The following is a description of a gene set: from publication Stein RA, Chang CY, Kazmin DA, Way J, Schroeder T, Wergin M, Dewhirst MW, McDonnell DP (PMID 18974123) Genes down-regulated by ESRRA only. studied in species Homo sapiens Human Gene Set: STEIN_ESRRA_TARGETS_DN Expression of estrogen-related receptor alpha (ERRalpha) has recently been shown to carry negative prognostic significance in breast and ovarian cancers. The specific role of this orphan nuclear receptor in tumor growth and progression, however, is yet to be fully understood. The significant homology between estrogen receptor alpha (ERalpha) and ERRalpha initially suggested that these receptors may have similar transcriptional targets. Using the well-characterized ERalpha-positive MCF-7 breast cancer cell line, we sought to gain a genome-wide picture of ERalpha-ERRalpha cross-talk using an unbiased microarray approach. In addition to generating a host of novel ERRalpha target genes, this study yielded the surprising result that most ERRalpha-regulated genes are unrelated to estrogen signaling. The relatively small number of genes regulated by both ERalpha and ERRalpha led us to expand our study to the more aggressive and less clinically treatable ERalpha-negative class of breast cancers. In this setting, we found that ERRalpha expression is required for the basal level of expression of many known and novel ERRalpha target genes. Introduction of a small interfering RNA directed to ERRalpha into the highly aggressive breast carcinoma MDA-MB-231 cell line dramatically reduced the migratory potential of these cells. Although stable knockdown of ERRalpha expression in MDA-MB-231 cells had no effect on in vitro cell proliferation, a significant reduction of tumor growth rate was observed when these cells were implanted as xenografts. Our results confirm a role for ERRalpha in breast cancer growth and highlight it as a potential therapeutic target for estrogen receptor-negative breast cancer., and this is the list of marker genes: HPF1, CCNG2, CLDN3, RHBDF1, PDCL, EFCAB14, ARID4A, LAMB1, CYP1B1, EXOSC2 (NCBI Gene Id 23404), BRD3, OCLNP1, YPEL5, NAP1L1, PRKAR2B, MYO6 (myosin VI), CSNK1G2, TACC1, BRD3OS, TRIO, TFE3, CDC23, CYBC1, RGS19, SEPTIN8, PLAU, MARCKS, MSH6, INTS12, ZNF24 (NCBI Gene Id 7744), VANGL1, TRMT112 (tRNA methyltransferase activator subunit 11-2), RABIF, DHX40, ATG2B, PPL, PMM1, SEC14L1, SLC37A4, TNFRSF11B, RBFOX2, FGFR3, MORC2, ADRA2C, GNPDA1, DENND10P1, SIGMAR1, DGUOK, BPTF, KIDINS220, NR2F2, TERF1, ZNF7, UCK2, HLA-E, DCTD, ZHX3 (zinc fingers and homeoboxes 3), TNFAIP8, GTF2B, BOP1, GATAD1, TCAF1, HEXIM1, PRKD2, CAV2, TIGAR, ZNF45, DBNDD1, SLCO1A2 (NCBI Gene Id 6579), TRIM8, H2BC10, TGFBR2, SMARCC1, PEA15, MXD4, TUBB6, KANK2, TRAM2, SSB, DAXX, ASB6, ANXA2P3, DCAF15, UTP25, ZNF134, PRPS2, BMP7, ZNF514, GFPT1 (NCBI Gene Id 2673), TUBD1, PATZ1, RFXANK, CIZ1, B4GAT1, PHIP, FAM174B, CLDN1, PLS1, LRRC41, VDR, FZD2, MBD4, CST6, NOL6, CMTR1